The following is a description of a gene set: Cytokines mediate cell-cell communication in the immune system and represent important therapeutic targets. A myriad of studies have highlighted their central role in immune function, yet we lack a global view of the cellular responses of each immune cell type to each cytokine. To address this gap, the authors created the Immune Dictionary, a compendium of single-cell transcriptomic profiles of more than 17 immune cell types in response to each of 86 cytokines (>1,400 cytokine-cell type combinations) in mouse lymph nodes in vivo. A cytokine-centric view of the dictionary revealed that most cytokines induce highly cell-type-specific responses. For example, the inflammatory cytokine interleukin-1β induces distinct gene programmes in almost every cell type. A cell-type-centric view of the dictionary identified more than 66 cytokine-driven cellular polarization states across immune cell types, including previously uncharacterized states such as an interleukin-18-induced polyfunctional natural killer cell state. studied in species Mus musculus Genes positively differentially expressed in cell type: Langerhans upon treatment with cytokine: IL-3 in mouse lymph nodes in vivo. from publication Cui A, Huang T, Li S, Ma A, Pérez JL, Sander C, Keskin DB, Wu CJ, Fraenkel E, Hacohen N (PMID 38057668) Mouse Gene Set: CUI_LANGERHANS_IL3_RESPONSE_UP, and this is the list of marker genes: Myadm (NCBI Gene Id 50918), Plgrkt, Tsen34, Gnai2, Esyt2, Adgrg6, Socs2, Zfand6, Vim, Cd302, Snd1, Map3k14, Coro2a, Gbp5, Bcl2a1d, Rabgap1l, Plek2, Irf5, Cd274, Tcaf2, Uap1, Jak2, Gpbp1, Diaph1, Kif1b (NCBI Gene Id 16561), Olfm1, Csf2rb2, Mfhas1, H1f10 (NCBI Gene Id 243529), Csf2rb, Nr4a3, Nckap1l, Ccl17 (C-C motif chemokine ligand 17), Anxa5, Rap2a, Serpina3g (NCBI Gene Id 20715), Samhd1, Rac3, Cst3, Ahnak, Prkcd, Mllt6, Mylk, Jaml, Ncoa3, Taldo1, Cyfip1, Eif3a, Wsb1, Bcl2a1b, Ccl22, Necap2, Cdkn1a, Stxbp6, Bcl2a1a, Orai1